The following is a description of a gene set: Human Gene Set: WP_SARSCOV2_AND_ACE2_RECEPTOR_MOLECULAR_MECHANISMS SARS-CoV-2 and ACE2 receptor: molecular mechanisms species: Homo sapiens, and this is the list of marker genes: TMPRSS2, AGT, ACE2, ACE, MAS1, AGTR1, REN